The following is a description of a gene set: studied in species Homo sapiens Human Gene Set: WP_AMPLIFICATION_AND_EXPANSION_OF_ONCOGENIC_PATHWAYS_AS_METASTATIC_TRAITS Amplification and expansion of oncogenic pathways as metastatic traits, and this is the list of marker genes: NOTCH1, EPAS1, SRC, VHL, CXCR4, TNC, WNT2, VEGFA, TCF7L2, POSTN, TCF7, VCAM1, PIK3CG, TCF7L1, CYTIP, LEF1, JAG1